Given this list of marker genes CHMP4C, MVB12A, LRSAM1, NEDD4, TSG101, MVB12B, CHMP7, VPS37B, CHMP5, PDCD6IP, VPS37C, VPS37D, CHMP2A, CHMP3, CHMP1B, CHMP4B, CHMP2B, CHMP1A, VPS4A, VPS37A, CHMP6, CHMP4A, MITD1, VPS28, CHMP4BP1, VPS4B, here is a description of the gene set: Human Gene Set: GOBP_VIRAL_BUDDING studied in species Homo sapiens A viral process by which enveloped viruses acquire a host-derived membrane enriched in viral proteins to form their external envelope. The process starts when nucleocapsids, assembled or in the process of being built, induce formation of a membrane curvature in the host plasma or organelle membrane and wrap up in the forming bud. The process ends when the bud is eventually pinched off by membrane scission to release the enveloped particle into the lumenal or extracellular space.